Given this list of marker genes Cenpc1, Cenph, Cenpe, Cenpx, Dlgap5, Cenpk, Nasp, Cenpp, Trappc12, Cenpw, Cenpa, Senp6, Cenpv, Itgb3bp, Sugt1, Mis18a, Mis12, Kntc1 (NCBI Gene Id 208628), H3f3b, Pogz, Cenpn, Cenpo, Oip5, Hjurp, Cenpt, Cenpi, Rnf4, here is a description of the gene set: studied in species Mus musculus The aggregation, arrangement and bonding together of proteins and centromeric DNA molecules to form a centromeric protein-DNA complex. Includes the formation of the chromatin structures which form a platform for the kinetochore, and assembly of the kinetochore onto this specialized chromatin. In fission yeast and higher eukaryotes this process also includes the formation of heterochromatin at the outer repeat (pericentric) regions of the centromere. Mouse Gene Set: GOBP_CENTROMERE_COMPLEX_ASSEMBLY